The following is a description of a gene set: Human Gene Set: GSE22886_TCELL_VS_BCELL_NAIVE_DN Immune cell-specific expression is one indication of the importance of a gene's role in the immune response. In order to identify such patterns, we set out to broadly profile gene expression in a variety of immune cells. from publication Abbas AR, Baldwin D, Ma Y, Ouyang W, Gurney A, Martin F, Fong S, van Lookeren Campagne M, Godowski P, Williams PM, Chan AC, Clark HF (PMID 15789058) species: Homo sapiens Genes down-regulated in comparison of naive CD4 CD8 T cells versus naive B cells., and this is the list of marker genes: PI15, CD79B, CEP43, ZNF552, GPM6A, FPR2, GPATCH2L, SCML2, HLA-DOA, TIAM2, CNR1, GATM (glycine amidinotransferase), TULP2, PIK3C2B, DIAPH3, IRF8, VSIG10 (V-set and immunoglobulin domain containing 10), PGR, MIR600HG, SCN3A, PLPP3, MS4A1, GTPBP3, KMO, TNFSF4, CLCN4, PKIG, ZNF532, USP2, PARM1, COBLL1, BLNK, HESX1, LARGE1, NEIL3, SPIB, TSPYL5, NCKIPSD, FBLN1, RUBCNL, SOBP, NIPSNAP3B, CHL1, BACE2, MYEF2, FRAS1, H4C6, MAGEA4, LY86, CLMN, PAWR, BANK1, HLA-DMB, RHPN1-AS1, NOD1, PEG10, BCL7A, MYO1B, TSPAN13, ATXN3, HLA-DOB, GSTA1, ZNF112, TNS3, RHD, AP1G1, IL13RA1, CD79A, COL9A2 (NCBI Gene Id 1905), HMGCS1, FGF7, SOX5, TCL6, SEMA4F, SLC12A2, GSTA4, CD80, HCN4, UGT2B15, PRPH2, CLCN6, DDR1, DMC1, IL24, MYOZ3, PHLPP2, DSP, KATNBL1, IFNA4, CTNNAL1, UTP25, ZNF682, ZNF747, CSRNP3, CNR2, GRK3, ZNF606, RHOBTB1, FOXN2, SLC6A16, IFNA7, GCNT1, P2RX5, ANKRD34C, PTGS1, VPREB3, CLEC4A, TIMELESS, TCF4, CLEC4E, VAV2, DCAF17, FZD10, FMO5, MAS1, RIPOR1, FAM30A (NCBI Gene Id 9834), TAF4B, TCL1A, MAGEA3, TBC1D19, ADAM19, IL1R1, HLA-DMA, TMEM156, FBXO4, SBNO1 (strawberry notch homolog 1), PLCG2, ABCA1, CCP110, DPPA4, CHST4, DLG5, GJA9, LAMC1, IDI2-AS1, SPOCK1, MID1 (NCBI Gene Id 8230), DNMBP, MTCL1, SNX13, TFPI2, MTMR10, CORO2B, MTCL2, DPF3, FCRL2, SLC24A1, COLEC10, MPZL1, GM2A, CD19, HILPDA, KYNU, LIMK2, MARCHF3, CD1D, COLEC12, DTX4, CNKSR2, ATPAF2, SAMD4A, CD72, TSHB, SLC9A7 (NCBI Gene Id 84679, solute carrier family 9 member A7), TREML2, PIP5K1B, CDK14, SEMA3C, FADS3, CD200, CD22, RAB30, CD180, ATP10D, HDAC9, DBNDD1, HBBP1, PDE10A, CRHR2, SMR3B, HHEX, POLR1HASP, ENTPD1, SERPINB5, BCL2L2, BCL11A, FCGR2B, SMPX, PNOC, HYDIN, KCNJ2, STAP1, RIC3, STRN3, MEF2C, CCDC170, BTK